Given this list of marker genes FOXC1, NCAPG2, NDUFB11, PITX2, HCCS, TRIM44, B3GLCT, FKRP, RERE, PITX3, COX7B, CYP1B1, DNA2, KDM6A, POMT1, CENPF, POMT2, FOXE3, WDR37, PAX6, CDH2, KMT2D, LARGE1, PRR12, CRPPA, MAF, FKTN, here is a description of the gene set: Human Gene Set: HP_PETERS_ANOMALY studied in species Homo sapiens A form of anterior segment dysgenesis in which abnormal cleavage of the anterior chamber occurs. Peters anomaly is characterized by central, paracentral, or complete corneal opacity. Peters anomaly